Given this list of marker genes Pxn, Gab1, Btc, Epgn, Tgfa, Pag1, Csk, Grb2, Egfr, Areg, here is a description of the gene set: This event has been computationally inferred from an event that has been demonstrated in another species.<p>The inference is based on the homology mapping from PANTHER. Briefly, reactions for which all involved PhysicalEntities (in input, output and catalyst) have a mapped orthologue/paralogue (for complexes at least 75% of components must have a mapping) are inferred to the other species. Reactome Pathway: GAB1 signalosome electronically inferred by orthology from the curated human pathway species: Mus musculus part of: Signaling by EGFR